The following is a description of a gene set: Any process that stops, prevents or reduces the rate or extent of cell adhesion to another cell. species: Homo sapiens Human Gene Set: GOBP_NEGATIVE_REGULATION_OF_CELL_CELL_ADHESION, and this is the list of marker genes: CD274, GLMN, FOXP3, CEACAM1, IHH (Indian hedgehog signaling molecule), SHH, VTCN1, FXYD5, PLA2G2A, ARG2, PAG1, LGALS9, NRARP, HLX, TBX21, CTSG, RC3H1, SFTPD, LGALS9B, LGALS1, MDK, IRF1, RGCC, ABCA12, LAX1, HLA-G, IL2RA, TNFAIP8L2, PTPN6, IFNB1, C1QTNF1, CD37, ILDR2, MBP, TGFB1, NOTCH4, MIR146A, TMEM131L, KLF4, IDO1, ANXA1, NDFIP1, CDH1, TWSG1, CD300A, PTPN22, SPI1, YTHDF2, SH2B3, PELI1, ADAMTS18, MAPK7, APOA1, PTK2, SCGB1A1, MIRLET7E, HAVCR2, FGL2, PPARA, SOCS5, HFE, SPECC1L (sperm antigen with calponin homology and coiled-coil domains 1 like), CDKN2A, ADIPOQ, ALOX12 (NCBI Gene Id 239, arachidonate 12-lipoxygenase, 12S type), MIRLET7G, BTN2A2, MIR141, TARM1, DUSP22, TNR, CXCL12, CD9, PAWR, MAP2K5, IL4I1, CLEC4G, ZNF703, CEBPB, RUNX1, LGALS9C, WNK1, SWAP70, WNT1, CRTAM, VSIG4, SLC4A2, BMP4, NOTCH1, MIR31, PRNP, CD80, ITCH, B4GALNT2, LRRC32, IL20RB (NCBI Gene Id 53833), BTLA, AKNA, HMGB1, SOCS1, LILRB1, ZBTB7B, FGL1, DTX1, ADORA2A, ASS1, CCL25, CCL21, IL4R, LAPTM5, LILRB2, IL1RN, PLG, DLG5 (discs large MAGUK scaffold protein 5), SCRIB, RUNX3, GLI3, LOXL3, ARG1, METTL3, RC3H2, PLA2G2D, STAT5A, ASCL2, MARCHF7, PPM1F, HLA-DRB1, IFNA2, TRPV4, GNRH1, VEGFA, FOXJ1, PLA2G5, PLA2G2F, CD74, BMP6, MIA3, TMX1, SMAD7, GPNMB, TNFSF18, MAP2K1, LILRB4, UFL1, MIR21, TNFRSF14, LGALS3, JAG1, CR1, MYADM, CDSN, DLG1, ABL1, CCL28, RIPOR2, CASP3, PRDX2, EPB41L5, MIR222, CD86, ERBB2, MAD1L1, MIR125A, JAK2, RAG2, GTPBP4, TNFRSF21, SPN, MIR181C, CSK, IL2, PTPN11, PRKG1, MIR221, VSIR, CBFB, BMP2, PRKAR1A, SDC4, JAK3, TNFSF4, ZC3H12A, PTPN2, PDCD1LG2, BCL6, NEXMIF, TIGIT, MUC21, MIR30B, CTLA4, PODXL, AKT1, SERPINE2, IFNL1, SPINT2, ADTRP, CD69, HLA-E, EPCAM, DAPL1, CBLB, PRKCD, SOCS6, RDX, XCL1, UBASH3B, DUSP3, MIR27A, IL10, NF2, LAG3, TSPAN32, MAD2L2, PDCD1, ZC3H8 (zinc finger CCCH-type containing 8)